Given this list of marker genes Prkaa2, Sh3rf1, Prkar2b, Pabpc1, Mon2, Tspan2, Myo5a, Crebrf (CREB3 regulatory factor), Purb, Scn9a, Ms4a1, Tmem250, Mapk1, Tfap2b, Myt1, Slc12a2, Insm1, Fmnl2, Mctp1, Ppm1b, Qki, Cnot4, Atl2, Fgl2, Bmt2, Tomm6 (NCBI Gene Id 66119), Inpp4b, Ifi204 (interferon activated gene 204), Tmf1, Or2ag2b, Scn1a, Rnf11, Smim15, Cpeb3, Chsy3, Ndfip2, Slc24a5, Arrdc3, Cep170, Cobll1, Rnf180, Tob1, Actg1, Epc1, Tnfsf11, Msl2, Scml2, Plekha1, Khsrp, Ticam2, Lypd8l, Hif1a, Akap11, Wdr37, Cramp1, Nxpe4, Rufy3, Chic1 (NCBI Gene Id 331484), Clec4a2, Mitf, Appl1, Zfp329, Trappc13, Cep41, Phf6, Luc7l3, Pcdh17, Rc3h1, Gpcpd1 (glycerophosphocholine phosphodiesterase 1), Vkorc1l1, Ccdc71l, Xrcc4, Id4, Specc1, Myocd, Klhl8, Gpatch11, Cd55, Pid1, Herpud2, Mxi1, Rpusd2, Usp25, Ggcx, Dcbld2, Utp4, Riok3, Rnf2, Otud4, Arhgap26, Hcn1 (hyperpolarization activated cyclic nucleotide gated potassium channel 1), Igf2bp2, Cxcl13, Tmem8b, Hook3, Cnot6l, Stk17b, Cfi, Otud6b (OTU domain containing 6B), Gnai3, Slc17a8, Ripor1, Upf1, Aebp2, Map2, Ppfibp1, Camsap2, Caps2, Slc14a1, Man1a2, Cask, Jcad, Trps1, Fkbp14, Rps6ka3, Tmem170b, Obox6, Steep1, Btbd3, Fnip1, Prcp, Srpk2, Bicd2, Ints2, Zfp800, Gimap8, Fsd1l, Ino80d, Ficd, Vegfa, Sort1, Fgf12, Cpeb4, Clcn4, Tmed5, Ubr2, Edil3, Ryr2, Pcnp, Phf14, Pik3cg, Fut9, Sbno1, Cops4 (NCBI Gene Id 52442), Septin7 (septin 7), Samd3, Eif2d (NCBI Gene Id 51958), Rhbdf2, Bltp3b, Pabpc5, Atp2c1, Snx27, Kctd3, Cntnap1, Jph1 (junctophilin 1), Vcan, St7l, Wdr44, Selenop, Pds5b, Slc1a1, Zfand3, Eif3a, Lins1, Bcl11a (NCBI Gene Id 72708), Nup153, Cacna1c, Mcfd2, Nup35, Rab21, Tcf20, Suz12, Kcnj13, Fam124b, Or5m3b, Map4k3, Nog, Mmgt1, Itga6 (integrin alpha 6), Hps3, Dusp7, Il21, Adgre4, Trip4, Phf21b, Tardbp, Tubal3, Asph, Fbxl5, Pcmtd1, Ogt, Tead1, Rims2, Mier3 (MIER family member 3), Prss35, Slk, Npas3, Aldh6a1, Nr1d2, Dram1, Fam120a, Tent4b, Gucy1a2, Col10a1, Rps6kb1, Arih1, App, Rap2c, Garre1, Bbip1, Hecw2, Greb1l, Hunk, Cadm2, Otc, Dhx15, Nsmce2, Chd9, Elapor2, Crbn, Gcc1, Tpr, Shprh, Xiap, Npr3, Dpp9, B230219D22Rik, Hyou1, Tmtc1 (NCBI Gene Id 387314), Tlcd4, Ptar1, Tapt1, Pxdc1, Rest, Megf11, Dmrta1, H2aj, Ipo5, Thsd7a, Npnt, Fam193b, Fgd4, Ccdc122, Syncrip, Kmt5a, Cdk12, Zbtb7a, Rabgap1l, Necab1, Rilpl2, Kdm1b, Frmd4a, Zfp788, Supt16, Brinp2, Hipk1, Lrrn1, Asz1, Yy1 (NCBI Gene Id 22632), U2surp, Plppr4, Sestd1, Fut8, Nol4, Rc3h2, Bicd1, Sec62, Tut4, Foxj3, Gabra4, Rbfox2, Kcne2, Fasl, Gm5591, Crybg3, G2e3, Nr2c1, Slc23a2, Actr2, Trappc8 (NCBI Gene Id 75964), Gosr1 (NCBI Gene Id 53879), Slc7a11, Wasl, Spast, Atp6v1e1, Pik3ca, Nfat5, Ulk2, Tgs1, Fndc3b, Lingo2, Zfp503, Synj2bp, Glt8d2, Aifm1, Sall1, Negr1, Fnip2, Zfp608, Hdx, Zmym2, Nhsl2, Tnrc6b, Chp1, Naa30, Senp6, Pnpla8, Fbxo33, Polr1g, Neurod4, Pcdhb16, Pbx1, Arap2, Lrrc58, Pcdhb3, Tgfbr2, Clec2e, Oprk1, Nalcn, Ndst4, Mfsd11, Dcaf6, Sp4, Zbtb44, Golt1b, Nck2, Sucla2, Traf4, Map3k2, Zfp644, Ippk, Kpna6, Ubxn7, Pde3b, Syap1, Ttc13, Irs1, Zfp710, Ifi203, Epn2, Dmd, Arsk, Igsf11, H2-Q1, Tbc1d15, Atp6v1h, Btf3, Tbl1xr1, Pls3, 1700102P08Rik, Cyp2c70, here is a description of the gene set: Genes predicted to be targets of miRBase v22 microRNA mmu_miR_186_5p in miRDB v6.0 with MirTarget v4 prediction scores > 80 (high confidence targets). from publication Chen Y, Wang X (PMID 31504780) studied in species Mus musculus Mouse Gene Set: MIR_186_5P